Given this list of marker genes UBE2C, H2AZ1, STMN1, BIRC5, UBE2T, RPA3, TUBB, DNAJC9, ASPM, SMC4, SMC2, NUDT1, NUSAP1, ZWINT, CCNA2, TOP2A, CKS1B, AURKB, TK1, CENPM, H4C3, PCNA, DDX39A, KIF22, PCLAF, CDKN3, DEK, TUBA1B, CARHSP1, PTTG1, HMGB2, HMGN2, TMEM106C, DUT, MKI67 (marker of proliferation Ki-67), TMPO, MAD2L1, TUBB4B, RANBP1, CKS2, CDK1, TYMS, H2AZ2, FABP5, MCM7, SIVA1, TPX2, RRM2, CENPF, here is a description of the gene set: Genes upregulated in subsets of cells of a given type within various tumors studied in species Homo sapiens In this study, an extensive analysis was conducted to define meta-programs (MPs) capturing intra-tumor heterogeneity across a spectrum of tumor types. The approach utilized non-negative matrix factorization (NMF) to analyze each cell type separately within individual tumor samples. This involved the analysis of malignant cells, macrophages, fibroblasts, endothelial cells, epithelial cells, T-cells, and B-cells. NMF was executed with varying parameter values (K=4, 5, 6, 7, 8, 9), thereby generating 39 programs for each cell type per sample. Each NMF program was summarized by the top genes based on NMF coefficients.\nRobust MPs were then delineated for each cell type using a set of stringent criteria, including recurrence within the same tumor, similarity to programs in other tumors, and non-redundancy within a tumor. Subsequently, these robust NMF programs were clustered (per cell type) based on Jaccard similarity, leading to the identification of MPs associated with each cell type.\nTo enhance the quality of the MPs, a refinement steps were undertaken, involving the removal of MPs suspected of reflecting low-quality data (with an overrepresentation of ribosomal proteins or mitochondrial-encoded genes), single-study inclusion, or similarity to miss-annotated cell types. from publication Gavish A, Tyler M, Greenwald AC, Hoefflin R, Simkin D, Tschernichovsky R, Galili Darnell N, Somech E, Barbolin C, Antman T, Kovarsky D, Barrett T, Gonzalez Castro LN, Halder D, Chanoch-Myers R, Laffy J, Mints M, Wider A, Tal R, Spitzer A, Hara T, Raitses-Gurevich M, Stossel C, Golan T, Tirosh A, Suvà ML, Puram SV, Tirosh I (PMID 37258682) Human Gene Set: GAVISH_3CA_METAPROGRAM_CD8_T_CELLS_CELL_CYCLE